The following is a description of a gene set: Persistence of the hyaloid artery, which is the embryonic artery that runs from the optic disc to the posterior lens capsule may persist; the site of attachment may form an opacity. The hyaloid artery is a branch of the ophthalmic artery, and usually regresses completely before birth. This features results from a failure of regression of the hyaloid vessel, which supplies the primary vitreous during embryogenesis and normally regresses in the third trimester of pregnancy, leading to a particular form of posterior cataract. Remnants of the hyaloid vascular system species: Homo sapiens Human Gene Set: HP_REMNANTS_OF_THE_HYALOID_VASCULAR_SYSTEM, and this is the list of marker genes: NDP, NF2, PRR12, SIX3, COL11A1, PAX6, CRPPA, ATOH7, LAMB2, BCOR, ZSWIM6, SMC5 (NCBI Gene Id 23137), FZD4